Given this list of marker genes NECTIN1, FN1, ATRNL1, SLC39A10, ACOT2, GP1BB, MAN2A2, ST3GAL6, ANTXR2, SELENOP, ELL, TINAG, EMSY (NCBI Gene Id 56946), HEXB, BMPR1A, NDUFB5, ST6GAL1, PPP3R2, VKORC1, BNIP3L, TLCD4, ZBTB4, BRWD1, RHOBTB3, BMX, SRPX2, SNAP47, ABITRAM, RAB3B, CD163, TMEM216, AAMDC, CEP20, COL4A5, PYROXD2, WARS2, GHSR, KLHL35, CDC42EP3, PEG3, PRKACA, PKIA, KCNU1, GLO1, CYP3A7, COPG2IT1, CD300LD, CHST9, PARP1, MGP, AGL, FBP2, NDUFS7, LRRC56, KLHL9, TXNDC16, CTH, FBLN5, EIF4B, CHODL, COX7A2L, ARHGEF6, SGSH, APPL2, RBP7, TGFBR3, GPA33, SAR1B, INMT, RNF112, ENTPD5 (NCBI Gene Id 957), HOOK3 (hook microtubule tethering protein 3), REPS2, TIA1, ABCC9 (ATP binding cassette subfamily C member 9), BPGM, MORN5, UQCC6, HABP2, HBS1L, IPO7, GRB10, IL23A, TLE6, S100B, SLC30A9, MLF1, PNLIP, CACNA2D1, MROH2A, TSLP, SUCO, RHOQ, AKAP12, LMBR1, TIMM17B, AR, SYNM, FMO2, FNDC8, P4HTM, BTNL9, UCHL1, CSF1R, LYPLA1, EPOR, ANKMY2, UBE2H, ARHGAP19, ENPEP, WDR26, ODAM, VDAC3, CRYBG3, LRRC39, NFE2L3 (NFE2 like bZIP transcription factor 3), PNMA8B, BRINP3, EPHA6, RNASEH2C, IRS1, SLC39A6, TMEM109, RGS5 (regulator of G protein signaling 5), TTC3, PLCXD2, SLC17A2, SLCO2B1, COL26A1, PNCK, ZBTB26, PLAAT1, RNF150, STRADB, EDNRB, CCNG1, EFEMP1, INSIG2, SELENBP1, RPS3, FAP, FRAT2, STK26, SPINT2 (NCBI Gene Id 10653), LDOC1, ATP5MG, PGAP1 (NCBI Gene Id 80055), DCAF6, ZFYVE21, FN3K (fructosamine 3 kinase), EYA4, MRPL42 (NCBI Gene Id 64974), KLHL13, CMBL, VLDLR, PABPC4, RFTN2, ABCA9, RBM44, GPR34, ADGRL4, E2F6, AQP4, ZNF346, STYX, SS18L2, CRISPLD1, FERMT2, STAB1, FBXO3, ATRN, ZNF266, PDE2A, PAM, MAGEF1, EML5, GDF10, KLHL32, ZFAND6, TLL1, NFIA, SLC38A4, NDUFB10, TARS3, GNB5 (G protein subunit beta 5), RCAN2, ALDH1A3 (aldehyde dehydrogenase 1 family member A3), CYTL1, ATP5F1C, COX6C, HERPUD1, SERINC5, TNFRSF17, ASPH (aspartate beta-hydroxylase), NTN4, SEPTIN12, CYP2D6, ELAPOR1, UQCRC2, PHYHD1, here is a description of the gene set: studied in species Homo sapiens from publication Baram D, Dekel O, Mekori YA, Sagi-Eisenberg R (PMID 20190146) Genes up-regulated in HMC-1 (mast leukemia) cells: untreated versus incubated with the peptide ALL1 followed by stimulation with T cell membranes. We demonstrate that the G protein Gi3 is the cellular target of the adenosine A3 receptor (A3R). By using a cell permeable peptide comprising the C-terminal end of Gαi3 fused to an importation sequence (ALL1) as a selective inhibitor of Gi3 signaling, we show that by coupling to Gi3, the A3R stimulates multiple signaling pathways in human mast cells, leading to upregulation of cytokines, chemokines and growth factors.Following contact with activated T cell membranes, endogenous adenosine binds to and activates the A3R, resulting in Gi3-mediated signaling. Specifically, the majority of ERK1/2 signaling initiated by contact with activated T cell membranes, is mediated by Gi3, giving rise to ALL1-inhibitable cellular responses. These results unveil the physiological GPCR that couples to Gi3 and establish the important role played by this G-protein in inflammatory conditions that involve adenosine-activated mast cells. We used microarrays to detail the effect of ALL1 on gene expression of HMC-1 cells activated directly by the A3 receptor, or by contact with activated T cell membranes. Human Gene Set: GSE19888_CTRL_VS_TCELL_MEMBRANES_ACT_MAST_CELL_PRETREAT_A3R_INH_UP